Given this list of marker genes Rad51b, Atad5, Rcc2, Cdc25a, Cdk4, Hspa2, Wnt10b, Npm1, Dtl, Mta3, Cdk1, Rrm1, Rrm2b, App, Camk2d, Rad51c, Dyrk3, Ccnb1-ps, Ccnb1, Lmnb1, Stox1, Cdc25b, Smarcd3, Pbx1 (pre B cell leukemia homeobox 1), Brd4, Vps4b, Ccnd1, Fbxo5, Cdc7, Rab11a, Cdc25c, Sin3a, here is a description of the gene set: Mouse Gene Set: GOBP_POSITIVE_REGULATION_OF_CELL_CYCLE_G2_M_PHASE_TRANSITION Any signaling pathway that activates or increases the activity of a cell cycle cyclin-dependent protein kinase to modulate the switch from G2 phase to M phase of the cell cycle. species: Mus musculus